Given this list of marker genes Eci2, Eno1b, Acbd5, Gsto2, Ampd1, Plcd1, Elovl3, Gapdhrt, Gde1, Ttc39b (tetratricopeptide repeat domain 39B), Oga (NCBI Gene Id 76055), Cyp39a1 (NCBI Gene Id 56050), Etfbkmt (NCBI Gene Id 320204), Ppat, Idi1, Afmid (NCBI Gene Id 71562), Edn1, Scd3 (stearoyl-coenzyme A desaturase 3), Nqo1, Gnpda1, Nudt12, Chka, Gstm4, Pfkm, Cyp2j6, Gnai3, Bcat2, Dpysl4, Chst15, Guca1b, Got1, Spp1, Atf4, Atic, Abcg3, Akt1 (thymoma viral proto-oncogene 1), Oas1e, Plin5, Dhrs4, Flcn, Slc17a1, Pla2g1b, Agk, Ndufa13, Akr1d1, Hsd17b6, Tk1, Acad12, Awat2, Gapdhrt2, Decr1, Hmgcll1, Rbks, Macrod2, Clpx, Cyp2j5 (NCBI Gene Id 13109), Hdc, Akr1c12, Ptgis, Plpp2 (phospholipid phosphatase 2), Thtpa, Slc35a1, Gamt, Dolk, Gdpd1, Rptor, Nt5c1a, G6pd2, Bpgm, Fabp1, Pde10a, Dab2, Ahcy, Atp5f1e, Asl, Ak6, Tha1, Entpd8, Bco2, Dbil5, Mas1, Prxl2c, Fis1, Upp1, Slc2a8, Hacd2, Ppcdc, Gls, Tecrl, Thap4, Shmt1, P4ha1, Rdh19, Cyp2s1, Fmo5, Cyp2r1, Adipor2, Glo1, Psph, Qng1, Mthfd2l, Noxred1, Fahd1, Hkdc1, Mogat1, Tgds, Abcd3, Antkmt, Cyp4f15, Plod2, Ncor1, Ces2h, Kdm1a, Tnfrsf1a, Cyp46a1, Slc25a18, Dbi, Naalad2, Adck2, Asnsd1, Sptlc3, Dpyd, Plod3, Pdhx, Rdh7, Comt, Blvra, Arl2, Mrps36, Nagk, Mup11, Mbtps1, Ndufs3, Ptgdr, Pgls, Pgm2l1, Pde2a, Lias, Acsm5, mt-Nd4, Ass1, Pnpla8, Pnp, Nme1, Cfh, Itpa, Gstp-ps, Ptgr1, Ak1, Phkb, Qprt, Ier3, Man1c1, Dmgdh, Pcbd1, Clstn3, Pank3, Entpd1, Alox8, Aldh18a1, Dagla, Tff3, Rpia, C1qtnf12, Gsto1, Zbtb7a, Hpdl, Nln, Igf1, Scarb1, Ptges, mt-Atp8, Lipa, Appl2, Mthfr, Cyp26c1, Mccc1 (NCBI Gene Id 97117), Rorc, Slc22a13, Fads1, Mlx, Fh1, Dhodh, Pfkfb4 (6-phosphofructo-2-kinase/fructose-2,6-biphosphatase 4), Hsd17b7, Galt, Degs2, Cad, Slc39a8, Pltp, Slc52a2, Snord34 (small nucleolar RNA, C/D box 34), Idh2, Degs1, Dhcr7, Rab23, Mir143, Hsd17b12, Ces2e (carboxylesterase 2E), Usp7, Tph1 (tryptophan hydroxylase 1), Hnf1a, Pde8a, Trp53, Fads2b, Dgkq (diacylglycerol kinase, theta), Ncf1, Coq9, Hlcs, Trex1, Acot4, Naprt, Pex2, Cyp2d11, Idi2, Dao, Adcy2, Snord35a, Urah, Clybl, Pde4d, Nppa, Brat1 (BRCA1-associated ATM activator 1), Fmo3, Acss3, Me1, Them4, Reg3g, Phyh, Ndufb6 (NCBI Gene Id 277815), Adcy1, Mecr, Nudt1, Cyp2c69, Ppargc1a, Nppc, Syk, Mcrip2, Ptges2, Acacb, Slc2a1, Pde4a, Ttc36, Pten, Cnr1, Galk2, Coq3, Parp14, Actn3, Sec14l2, P4ha2 (NCBI Gene Id 97685), Snai2, Ephx3, Lmf1, Pgm2 (NCBI Gene Id 66681), Mlxipl, Rpe, Stat3, Txnrd1, Slc16a1, Sirt7, Tlr2, Dmac2l, Atf3, Pdk4, Amacr, Myof, Cyp2j12, Ppp1ca, Kcnq1, Sult2b1, Aldh3a2, Suclg1, Nr1d1, Elovl1 (NCBI Gene Id 99961), Plaat1, Acadvl, B4galt1, Cnp, Pdss2, Slc27a6, Trib3, Lpin2, Slc7a11, Olah, Naxe, Cyp8b1, Fabp5, Ahcyl2, Nnt, Pdhb, Ank (NCBI Gene Id 52488), Mfsd2a, Oprm1, Vkorc1l1, Sult2a5, Amdhd2, Alpl, Hagh, Ip6k3, App, Mapk1, Pdxp, Acer1, Hal, Uros, B4galnt2, Cyb5r3, Stk11, Agps, Nme2, G6pc3, Msmo1, Fuom, Acad9, Kyat3 (NCBI Gene Id 229905), Lipc, Dkk3, Mgat1, Egr1, Cyp4a31, Acsbg1, Ces1h, Csl (NCBI Gene Id 71832), Sarm1, Acoxl, Slc25a2, Cyp2a5, Gfus, Ugt2a1, Eno2, Pgam2, Letmd1, Cbr4, Serpina12, Oxsm, Ncf2, Nanp, Gmppb, Prodh, Dcaf5, Aldh1l2, Cyp2a12, Alox5, Ppp2ca, Ddc, Ednrb, Lpin1, Ndufab1, Sorbs1, Ero1b, Ip6k2, Atp1a3, Ndufa6, Eci1, C3, Prkab2, Pth2, Mpst, Kit, Ins1, Mdh1, Lima1, Cyp2d34, Sord, Apob (apolipoprotein B), Foxo1 (forkhead box O1), Pex13, Nudt16, Pnp2, Mblac2, Ak8, Cbs, Coq4, Aldh5a1, Pemt, Pla2g6, Ndufa10, Atp5pd, Sptlc1, mt-Nd4l, Shmt2, Atp1b1, Naxd, Nt5m, Ppip5k2, Avp, Elovl4, Pck1, Mthfd1l, Aldh3b2, Amn, Cyp2c70, Nos1, Acp3, Crtap, Slc1a3, Gsta1, Echdc1, Gars1, Dck, Oxct2a, Gykl1, Hoga1, Ppip5k1, Oat, Nudt3, Gk5, Dglucy (D-glutamate cyclase), Mme, Asah1 (N-acylsphingosine amidohydrolase 1), Nudt15, Gk2, Atp6-ps, Adh1, Ndufv3, Rdh13, Carmil1, Cdo1, Dlat, Adal (NCBI Gene Id 75894), B3galnt2, Gpd2, Atp6v1b2, Nt5c2, Gnai1, Acsf3, Bglap, Gpt2, Pgk1, Agxt, Npr2, mt-Nd1, Chst1, Akr1a1, Ncoa2, Gatd1, Pparg, Rnaseh2b, Nmnat3, Gck, Rdh11, Npc1, Entpd4b, Cthrc1, Gstm3, Gale, Mat2a, Tlr4 (toll-like receptor 4), Nos3, Npr1, Mmab, P2ry1, Park7, Htt, Plaa, Dnm1l (NCBI Gene Id 74006), Uap1, Ndufa11 (NADH:ubiquinone oxidoreductase subunit A11), Irs1, Aldh8a1, Ndufv2, Cyp1a1, Chpt1, Nt5c3b, Pon1, Slc23a2, L2hgdh, Scnn1b, Acmsd, Cyp2c54, Crtc2, Ebp, Rbp1, Isyna1, Rpe65, Gnpda2, Adipor1, Aox1, Tm7sf2, Col6a1, Alkbh7, Kmo, Elovl2, Cav1, Sfxn3, Galk1, Scd4, Ndufv1, Rbp4, Lrp1, Cyp2d9, Pik3r1, Myh7, Pmp22, Mlst8, Stard4, Prkab1 (NCBI Gene Id 76283), Gapdhs, Alox12e, Uchl1, Aldoc, Coq2, Ces1f, Kars1, Il4i1, Aadat, Fgf23, Abhd1, Sco1, Pde5a, Glb1l3, Sephs1, Acsl6, Pmaip1, Gpx4, Enpp5, Atp5f1a, Impa2, Trim63, Mat2b, Ubiad1, Tnxb, Pnliprp2, Acsm2, Ak3, Bad, Lipe, Akr1c14, Lpin3, Akr1c20, Cyp2c37, Ttr, Inpp4a, Apoa5, Pfkl, Acaca, Cmas, Slc4a1, Ola1, Mogat2, Oxct2b, Xpc, Umps, Pm20d1, Clcn2, Supt20, Pde1a, Nkx1-1, Sgpp1, Rrm1, Ldhb, Ak4, Slc25a19, Per2, Lipg, Gpi1, Acer2, Ces1b, Sdha, Ndufa8, Dpep1, St3gal1, Alox15, Mri1, Eif6, Pudp, Aig1, Hnf4a, Pkm, Pla2g15, Eif2ak3, Uprt, Rdh8, Erlin2, Strap, Cox11, Plcb3, Slc4a4, Adtrp, Cyp2j9, Bin1, Baat, Gch1, Elovl5, Mthfd1 (methylenetetrahydrofolate dehydrogenase (NADP+ dependent), methenyltetrahydrofolate cyclohydrolase, formyltetrahydrofolate synthase), Rora, Cp, Srebf2, Ddb1, Gstm1, Ldc1, Slc17a3, Arpp19, Rdh16f2, Ldhal6b (lactate dehydrogenase A-like 6B), Thrb, Abcc2, Phkg1, Pgd, Car5a, Nt5c, Cyp2d10, Prxl2b, Ero1a, Stat5b (signal transducer and activator of transcription 5B), Mpo, Vnn1, Glul, Nme7, Gckr, Ndufb7, Klf9, Rest, Hpgds (hematopoietic prostaglandin D synthase), Opa1, Nmnat1, Hmgcs2, Snord33, Cyp4a32, Acot10, Ndufb9, Ptgs1, Pla2g5, Xylb, Prodh2, Qki, Fuca2, Hsd3b7, Fads2, Fgf15, Phka1, Mcee, Acsl5, Dera, Ldha, Sirt1, Scd2, Slc25a25, Sult2a7, Bcat1, Coasy, Nudt10, Cyp4v3, Pnpla3, Arg2, Moxd1, Gtpbp1, Pdk3, Acsbg2, Cbr3, Ggcx, Mthfd2, Apoe, Cd320, Dhdds, Ogdh, Myh6, Aqp8, Akr1b7, Elovl6, N6amt1, Acadsb, Zbtb20, Esrrb, Gm1110, Gstp3, Gldc, Akt2, Rrm2, Mlycd, Fuca1, Me2, Spr, Malrd1, Ppp1r3e, Gnmt, Cacna1h, Rdh10, Ppcs (phosphopantothenoylcysteine synthetase), Dpagt1, Dyrk2, Slc16a9, Dgat1, Tsku, Aldh1a3, Gpd1l, Sult2a6, Prkag1, Ak2, Dgat2, Extl3, Cyp2e1, Xdh, Lacc1, Cyp2d26, Cyp4a30b, Ankrd26, Bend3, Dbh, Man2b1, Echdc3, Aldob, Khk (ketohexokinase, NCBI Gene Id 16548), Bhmt1b, Soat1, Cpt1a, Aldh6a1, Pank2, Gfpt1, Gimap7, mt-Nd3, Pde7b, Asns, Hmgcs1, Prg3, Dcxr, Acad11, D2hgdh, Tbxas1, Apoc2l, Itpk1, Nceh1, Sfxn1, Daglb, Pid1, Cyp4a14, Cs (NCBI Gene Id 71548), Dhrs7b, Lrp2, Atp2b2, Irs2, Agmat, Acads, Atp1a2 (ATPase, Na+/K+ transporting, alpha 2 polypeptide), Pla2g2a, Uckl1, Ndufc2, Abcd2 (NCBI Gene Id 26874), Etfb, H6pd, Tecr (trans-2,3-enoyl-CoA reductase), Cda, Lhcgr, Cps1, Tph2, Dpysl3, Cyp2c40, Nans, Abcg4, Slc35c1, Inhba, Sp7, Adss2, Ido1, Pmm2, Nr5a2 (nuclear receptor subfamily 5, group A, member 2), Sephs2, Gstp1, Fabp2, Blmh, Rrm2b, Cyp11b1, Csad, Hsd17b4, Fahd2a, Mmaa, Crmp1 (NCBI Gene Id 12933), Pofut1, G6pc2, Dctd, Sptssb, Fbp2, Papss1 (NCBI Gene Id 99599), Ugdh, Mapk9, Asah2, Enpp4, Ces1c, Trem2, Cyp2c50 (cytochrome P450, family 2, subfamily c, polypeptide 50), Dguok, Mmachc, Mtarc2, Nupr1, 4933405O20Rik, Acad8, Hacd4, Gad2, Sesn2, Aldh1l1, Gnb3, Gucy2f, Nudt2, Haao, Entpd5, Crot, Lpl, Tyrp1, Sds, Oas1a, Gatm (glycine amidinotransferase (L-arginine:glycine amidinotransferase)), Ugt2a2, Star, Cbfa2t3, Lypla1, Cyp2c66 (NCBI Gene Id 69888), Fgfr1, Oas1f, Acot2, Slc27a3, Ctps1, Soat2, Gulo (gulonolactone (L-) oxidase), Cyp1b1, Smpdl3a, Fdx1, Got1l1, Ftcd, Ephx1, Fgfr4, Slc27a4, Taldo1, Art2a, Ifng, Sc5d, Urod, Man2a2, Sult1e1, Mthfs, Adhfe1, Fut8, Gucy1b1, Sox9, Cyp2j8, Plcb1, Lcn5, Acsm3, Scp2, Itpkb (inositol 1,4,5-trisphosphate 3-kinase B), Hacd3, Fignl1, Gip, Pdpn, Slc45a2, Mthfsl, Apc, Fads6, Acot9, Bcl10, Snca, Cpt2, Cyp2f2, Acsbg3, Sod1, Slc52a3, Gls2, Slc37a4, Dpep2, Ces2c (NCBI Gene Id 234671), Egln2, Mvk, Gnpat, Sdsl, Mbtps2, Ttc39d, Uevld, Gdf2, Ndufb1, Enpp3, Cacnb4, Acsl3, Pdk2, Apoa1, Ada, Cbr1, Ldlrap1, Gpam (glycerol-3-phosphate acyltransferase, mitochondrial), Gpld1, Hsd17b8, Cyp27b1 (NCBI Gene Id 216437), Cyp27a1, Phgdh, Slc25a51 (NCBI Gene Id 77670), Mmut, Ptges3, Impdh2, Acsl4, Kat2b, Pgp, Slc25a12 (solute carrier family 25 (mitochondrial carrier, Aralar), member 12), Angptl8, Sult2a3, Tkfc, Cyp26b1, Aldh1a7, Ubr4, Flad1, Agmo, Ghr (NCBI Gene Id 223275), Creb1, Nfkb1, Mup1, Bglap2, Ptgs2 (prostaglandin-endoperoxide synthase 2), Pla2g4a, Ppm1k, Nme4, Aasdhppt, Edn2, Vnn3, Cebpa (NCBI Gene Id 12606), Lrat, Got2, Aprt, Atp5mc2, Hibadh, Hdac4, Renbp, Nudt7, Il3, Mmadhc, Gcsh, Fabp4, Vcp, Impdh2-ps, Hprt1, Auh, Atpsckmt, Hadha, Pex5, Stard3, Uggt1, Fah, Rdh1, Pdzd11, Abcd1, Vldlr, Cmpk2, Cyp2c23, Il1b, Adh5, Dct, Cyp11b2, Aldh2, Dnajc30, Myog, Slc2a9, Rdh9, Fpgs, Oas1d, Fa2h, Ogt, Errfi1, Ppa2, Cat, Dhtkd1, Pla2g4f, Myh9, Extl2, Sirt4, Gpd1 (glycerol-3-phosphate dehydrogenase 1 (soluble)), Slc25a22, Atp6v1a, Ak7 (NCBI Gene Id 78801), Azin2, Tdo2, Tysnd1, Tnfsf4, Cyp2d22, Enpp1 (NCBI Gene Id 97628), Tk2, Twist1, Apip, Nnmt, Slc27a2, Fbn1, Il6, Pnliprp1, Pgm3, Pnkd, Ces2a, Ctns, Fdxr, Atp5f1c, Mgst3, Pfas, Adcy4, Cdadc1, Abcg2, Tat, Cyp11a1, Cyp26a1, Amdhd1, Gart, Pgam1, Pecr, Art2b, Apoa2, Pth1r, Rtn4ip1, Bhmt, mt-Atp6 (mitochondrially encoded ATP synthase 6), Atp5f1d, Faah, Pla2g10, Aifm2, Cyp3a44, Ndufa7, Slc25a13, Oard1, Prps2, Etfa, Epha2, Cyb5a, Sdhc, Acaa1b, Map2k1, Hint1, Arv1, Ptgr2, Smpd1, Cmah, Cyp2j7, Esd, Cyp2b19, Mtarc1, Akr1c21 (NCBI Gene Id 77337), Sdr16c5 (NCBI Gene Id 242285), Mtap, Cyp2j13, Efl1, Guk1, Grhpr, Hsd11b2, Akr1b1, Aasdh, Cyp2b23, Cyb5r4, Galr2, Fcsk, Npy1r, Bhmt2, Nus1, Sp1, Ddah1, Tet2, Igfbp4 (insulin-like growth factor binding protein 4), Gcg, Elovl7, Fpgt, Gstz1, Wnt4, Dbt, Gucy2g, Cyp3a41b, Glud1, Ndufb5, Papss2, Ndufa1, Cyp24a1, Akr1c6, Ampd3, Nme5, Gucy2c, Ppp4r3a, Cyp51, Srd5a3, Hao1, Abcd4, Paics, Oasl2, Pnpo, Pfkfb1, Lrp5 (NCBI Gene Id 16973), Kbtbd2, Pfkp, Nudt19, Sirt6, Hao2, Ch25h, Snai1, Nudt8, Cth, St6gal2, Miox, Gstm2, Noct, Tigar, Coq6, Pank1, Ucp3, Slc45a3, Paqr3, Cyp2w1, Anxa1, Ran, Fmo4 (flavin containing monooxygenase 4), Mrs2, Ndufb8, Pmm1, Tpk1, Oas1g, Adcy9, Scd1, Agxt2, Macroh2a1, Disp3, Mcfd2, Mid1ip1, Urad, Nr1h4, Slc19a2, Upb1, Dut, Pde8b, Prpsap2, Gper1, Hsd17b3, Otogl, Oas1b, Mtch2, Igfbp3, Psen1, Cyp2a4, Pex7, Aacs (NCBI Gene Id 78894), Slc37a2, Slc39a14, Cyp4f14, Epm2aip1, Ces1g, Ndufs5, Apobr, Cyp2b10, Thnsl2, Rdh16, Ip6k1, Ggt1, Mpc1, Gfi1, Cant1, Ces2f, Usf1, Dpys, Ndufs4, Nudt5, Fcer1a, Upp2, Akr1cl, Glb1, Foxk1, Mst1, Apoa4, Entpd4, Mdh2, Fhit, Echs1, Bmp2, Abhd5, Lpcat3, Adpgk, Idh3g, Aldh1b1, Ugt1a6a, Pdx1, Fgf1, Nudt17, Pdxdc1, Cln6, Slc5a3 (solute carrier family 5 (inositol transporters), member 3), Uox, Dhrs9, Sult1b1, Sptlc2, Aco1, Adcy7, Gpx1, Ipmk, Lcat, Acaa2, Sgpp2, Cyp1a2, Nppb, Gclc, Napepld, Cyp3a16, Fads3, Isx, Nr1h2, Zmpste24, Gne, Insig2, Atp5pb, mt-Nd2, Pcx, mt-Nd5, Tspo, C1qtnf3, Pla2g3, Ndufc1, Plpbp, Ggt5, Apoc1 (NCBI Gene Id 11812), Cftr, Cln3, Slc25a10, Ghsr, E2f1, Fasn, Adss1, Ugp2, Slc35b4, Atp8b1, Tbpl1, Pibf1, Crabp2, Prps1l1, Sptssa, Cyp2b13, Cyp4f13, Lbr, Erfe, Hmgcl (NCBI Gene Id 230831), Prkg1, Xiap, Adcyap1r1 (adenylate cyclase activating polypeptide 1 receptor 1), Carnmt1, Ech1, Inppl1, Obp2a, Eci3, Uck1, Atcay, Dpm2, Akr1c18, Sqle, Plcg1, Ntsr1, Slc16a3, Cyp2c67, Cyp2ab1, Mvd, Serp1, Nadk2, Hk3, Rdh14, Avpr1b, Arnt, Hgd, Mtrr, Csgalnact1, Cpt1b, Plb1, Adi1, Hk2, Ces1e, Macrod1, Cyp4a10, Cyp2u1, Acat2, Prdx4 (peroxiredoxin 4), Them5, Nox4 (NADPH oxidase 4), Hk1, Pdxk, Pdk1, Eno4, Ivd, Abca5, Cyp2c68, Gc, Slc7a7 (NCBI Gene Id 20540), Pycr1, Hadhb, Nudt18 (nudix hydrolase 18), Bco1, Tdh (L-threonine dehydrogenase), Ndufb10, Plp1, Gucy2d, Kdm3a, Cyp2c65, Ctps2, Mir199a-2, Mup5 (NCBI Gene Id 17844), Ak5, Slc27a1, Pde9a, Carns1, Acadm, Nmnat2, Angptl3, Adcy3, Gmps, Suclg2, Mecp2, Iyd, Impa1, Prkaca, Idh3a, Mup3, Gmpr2, Sdhd, Mccc2, Acot1, Abcb11, Gchfr, Abcc6, Mtln, Pdha2, Gad1, Aloxe3, Acss2, Plaat3, Dip2a, Lta4h, Acox3, Pla2g4d, Sardh, Kcnj11, Ndufb11, Enoph1, Slc25a16, Ak9, Ndufb3, Cyp2t4, Idh3b, Grk3, Ndufa3, Atp5mc3, Nt5e, Nmrk2, Rdh5, Slco1a6 (solute carrier organic anion transporter family, member 1a6), Ephx2, Ogdhl, Hsd17b1, Abcc1, Bola3, Dcakd, 3110082I17Rik, Lpcat2, Tmem86b (transmembrane protein 86B), Pip4p1, Sdhb, Lrrk2, Mdh1b, Ppara, Selenon, Aldh1a2, Plpp3 (phospholipid phosphatase 3), Gda, Naaa, Cyp3a41a, Aicda, Abcg1, Ces2g, Pla2g7 (phospholipase A2, group VII (platelet-activating factor acetylhydrolase, plasma)), Hspa1b, Cyp2j11, Nr3c1, Mpi, Prps1, Bckdhb, Oxct1, Odc1, Atp7a, Pdss1, Aspa, Pank4, Pals2, Folr1, Dnph1, Coq8a, Pon3, Snord32a (NCBI Gene Id 27209), Pter, Acer3, Fmo2, Src, Acot5, Impdh1, Gnpnat1 (glucosamine-phosphate N-acetyltransferase 1), Dhrs3, Gba2, Prkn, Kat2a, Pxmp4, C1qtnf2, Cbr1b, Nucb2, Acss1, Sult1c1, Hibch, Glb1l (galactosidase, beta 1-like), Dpysl5, Ces1a, G6pdx, Insig1, Adcy10, Acly, Ttpa, Pycr2, Abhd2 (NCBI Gene Id 67094), Peds1, Slc5a6, Aldh3b1, Adh6b, Psat1, Gk, Parp1, Glyat, Vdac1, Erlin1, Ganc, Pam, Cyp4a12b, Nat8l, Dpm1, Ddo, Prpsap1, Pou1f1, Cyp2c29, Uck2, Alpi, Dld, Cyp2b9, Ins2, Fabp6, Nqo2, Ndufs6, Gcdh, Dpm3, Icmt, Slc2a6, Atp5mc1, C1qtnf9, Sphk2, Nme6, Stat5a (NCBI Gene Id 20850), Hif1a, Guca1a, Ndufs8, Acad10, Adsl, Apon (NCBI Gene Id 28194), Cacna1a, Abhd4, Hspa8, Wdtc1, Akr1c13, Cyp4f40, Lypla2, Samhd1, Acsm1 (acyl-CoA synthetase medium-chain family member 1), Prox1, Sgpl1, Atg5lrt, Bcl2l13, Adh4, Alox5ap, Adipoq, Atp2b4, Pdha1, Prkaa1, Otc, Aldoart2, Bckdha, Me3, Pfkfb3, Ldhc, Acat1, Plpp1, Gfpt2, Htd2, Cyp3a11, Pth, Rhoq, Mir423, Ahcyl1, Mat1a (NCBI Gene Id 11720), Ampd2, Pde4c, Acsl1, Acot3, Hmgb1, Itpka, Gpt, Tgfb1, Bmp6, Mcat, Aldoa, Gba1, P4hb, Nmrk1, Haghl (hydroxyacylglutathione hydrolase-like), Aass, Aldoart1, Azin1, Prmt3, Fech, Acsf2 (NCBI Gene Id 264895), Kcnma1, Slc25a44, Atp5mf, Pptc7, Aspg, Cyp4f18 (NCBI Gene Id 72054), Oaz1, Saa1, Gadl1, Atp5if1, Adk, Lonp2, Prkcb, Aco2, Ndufa12, Ilvbl, Qdpr, Nampt, Nr1h3, Ndufa9, Coq7, Pals1, Ehhadh, Lep, Ndp, Acadl, Amt (NCBI Gene Id 434437), Uap1l1, Cpt1c, Pgm1, Ep300, Ceacam2, Pde7a, Sdr9c7, Apoc3, Etfdh, Mir214, Jmjd8, Coq5, Sik1, Kyat1, Mfsd8, Slc38a8, Bmncr, Cln8, Sphk1, Aldh4a1, Acot8, Pm20d2 (NCBI Gene Id 242377), Cry1, Sik2, Pipox, Cd244a, Aldh1a1, Dkkl1, Tkt, Pla2g4c, Mgll, Entpd7, Tcf7l2, Fdps, Pctp, Acot11, Nudt9, Nudt11, Fkrp, Sucla2, Nme3, Rac1, Adcy8, Sdhaf3, Ceacam1, Gucy2e, Hsd11b1, Cyp2g1, Atp5f1b, Htr2a, Srd5a2, Adh7, Cygb, Prkar2b, Atp5pf, Lss, Alox12b, Ldhd, Ndufs2, Glb1l2, Mttp, Ndufb2, Adra1b, Ndufb4, Mapk14, Ppp1r3g, Apof, Nadsyn1, Sirt5, Pklr (pyruvate kinase liver and red blood cell), Fmo1, Mgst2, Rd3, Prkaa2, Otog, Gucy1a1, Mtr, Slc25a11, Oma1, Ido2, Mgat4a, Nsdhl, Nudt13, Atp5mg, Fam3a, Hacl1, Parg, Selenoi, Dhfr, Nfe2l1, Ptgds, Slc19a3, Cmtm2a, Atp6v1b1, Pik3ca, Acot12, Gpat4, Apoc2, C1qtnf1, Myo5a, Bcl2l1, Rfk, St6gal1, Acbd7 (acyl-Coenzyme A binding domain containing 7), Prkag3, Apod, Cyp2c38, Gapdh, Gdpgp1, Ndufs7, Prkg2, Gstp2, Far2, Fgl1, Foxk2, Adh6a, Cryl1, Ucp2, Pcmt1, Mup4, As3mt, Oca2, Ndufa5, Stoml2, Brca1, Uxs1, Fabp3, Myc, Hdlbp, Tnf, Entpd2 (ectonucleoside triphosphate diphosphohydrolase 2), Pck2, Entpd3, Ptpn2, Dlst, Aspdh, Hpgd, Hectd4, Gstm7, Rhoa, Npc1l1, Tymp, Acsm4, Nisch, Hrh3, Git1, Cd74, Shpk, Acnat1, Pah, Myh8, Gmppa, Srr, Cyp2c55, Gstm6, Lepr, Il4, Ptges3-ps, Mfn1, Oas1h, G6pc1, Lpo, Slc25a42, Ndufs1, P2ry6, Hacd1, Tpi1, Gdf15, Th, Ndufa2 (NCBI Gene Id 17991), Acnat2, Npl, Synj2, Adcy6, Igf2 (insulin-like growth factor 2), Lcmt1, Ippk, Tmem135, Pgk2, Ahr, Mif, Ces1d, Lgsn, Kynu, Tyms, Man2b2, Itpkc, Gdpd3, Man2a1, Dpysl2, Ankrd23, Dysf, Acaa1a, Acot6, Nt5c1b, Fggy, Dctpp1, Mpc2, Cyp7a1, Moxd2, Uqcc3, Clk2, Pcsk9, Npc2, Bloc1s6, Ddit4, Lipf, Bmp5, Pofut2, Adora2b, Hyi, Tfap2b, Uroc1, Cyp2d12, mt-Nd6, Pnpla2, Atp5po, Acox2, Glyctk, Alox12, Onecut1, Cbr2, Eno1, Cyp7b1 (cytochrome P450, family 7, subfamily b, polypeptide 1), Man2c1, Cyp4a12a, Rgn, Arg1, Asrgl1, Dhrs7, Tmsb4x, Ces2b, Scap, Pycr3, Mtcl2, Galm, Aoah, Sult2a4, Abat, Hpd, Insr, Gpr146, Eno3, Slc38a1, Far1, Sult2a1, Ppard, Slc27a5 (solute carrier family 27 (fatty acid transporter), member 5), Pfkfb2, Btd, Gmpr, Ldlr, Fitm2, Fdft1, Prkag2, Dhcr24, Hmgcr, Nadk, Plek, Klhl25, Echdc2, Cyp19a1, Idh1, Wdr5, Prps1l3, Pla2g2f, Adcy5, Srebf1, ENSMUSG00000144291, Nudt4, Pcbd2, P2rx7, Hsd17b10, Rdh12, Slc4a7, Dhdh, Hadh, Phkg2, Akr1c19 (aldo-keto reductase family 1, member C19), Lpgat1, Scly, Aplp2, Bdh2, Slc22a12, Ppp4r3b, Nit2, Cyp2c39, Nt5c3, Pnlip, Abcc10, Cyp2a22, Abca2, Slc25a17, Ptafr, Cmpk1, Fbp1, Ppp1r3b, Oas1c, Plcg2, Acox1, Atp5me, Abcc9, Pts, Mup2, Gclm, Cyp4a29, Abhd3, Gmds, Myh3, Agt, Coq8b, Dtymk, Retsat, Gprc6a, Acot7, Zfp692, Slc16a12, Abca1, Nos2, Avpr1a, Ahcyl, Ranbp2, Cubn (cubilin), B3glct, Gcat, Ltc4s, Crat, Slc29a1, Vkorc1, Sirt2, Por, Bckdk (NCBI Gene Id 12041), Sult2a2, Sult2a8, Nags, Mtor, Pmvk, Decr2, Nudt14, here is a description of the gene set: studied in species Mus musculus The chemical reactions and pathways involving small molecules, any low molecular weight, monomeric, non-encoded molecule. Mouse Gene Set: GOBP_SMALL_MOLECULE_METABOLIC_PROCESS